The following is a description of a gene set: species: Mus musculus The chemical reactions and pathways resulting in the breakdown of tyrosine, an aromatic amino acid, 2-amino-3-(4-hydroxyphenyl)propanoic acid. Mouse Gene Set: GOBP_TYROSINE_CATABOLIC_PROCESS, and this is the list of marker genes: Fah, Il4i1, Gstz1, Hgd, Hpd (4-hydroxyphenylpyruvic acid dioxygenase), Tat